The following is a description of a gene set: Any process that stops, prevents or reduces the frequency, rate or extent of endoplasmic reticulum unfolded protein response. species: Homo sapiens Human Gene Set: GOBP_NEGATIVE_REGULATION_OF_ENDOPLASMIC_RETICULUM_UNFOLDED_PROTEIN_RESPONSE, and this is the list of marker genes: PTPN1, PPP1R15B (NCBI Gene Id 84919), BFAR, XBP1, PPP1R15A, NCK2, ABCA7, DNAJB9, TMBIM6, NCK1, DDRGK1, AKT3, AKT2 (AKT serine/threonine kinase 2), ATAD3A, HSPA5, WFS1, MIR199A1, UFL1, AKT1, CREBRF, ATF6B, RACK1